Given this list of marker genes Ube2c, Psmc4, Psmd13, Anapc2, Psma3, Psmb7, Ubb, Psmc2, Psmd12 (proteasome (prosome, macropain) 26S subunit, non-ATPase, 12), Psmb6, Psmd6, Psmb4, Psmd7 (NCBI Gene Id 17463), Psma6, Cdk1, Cdc23, Psmb5, Psmc6, Mad2l1, Psmc1, Psma4, Psma2, Cdc26, Anapc15, Ube2e1, Anapc7, Psmd1, Anapc10, Rps27a, Ube2s, Ube2d1, Psmc3, Psmc5, Psma1, Psma5, Psma7, Ccna1, here is a description of the gene set: part of: APC:Cdc20 mediated degradation of cell cycle proteins prior to satisfation of the cell cycle checkpoint electronically inferred by orthology from the curated human pathway This event has been computationally inferred from an event that has been demonstrated in another species.<p>The inference is based on the homology mapping from PANTHER. Briefly, reactions for which all involved PhysicalEntities (in input, output and catalyst) have a mapped orthologue/paralogue (for complexes at least 75% of components must have a mapping) are inferred to the other species. Reactome Pathway: Cdc20:Phospho-APC/C mediated degradation of Cyclin A studied in species Mus musculus